Given this list of marker genes BMP4, WNT9B, GPC3, GATA3, EPHA7, PAX2, EPHA4, OSR1, HNF1B, EFNB2, LHX1, here is a description of the gene set: species: Homo sapiens Human Gene Set: GOBP_NEPHRIC_DUCT_MORPHOGENESIS The process in which the anatomical structures of the nephric duct are generated and organized. A nephric duct is a tube that drains a primitive kidney.